Given this list of marker genes ZMYND8, ZNF804A, NEDD9, INS, APOE, here is a description of the gene set: Any process that activates or increases the frequency, rate or extent of dendritic spine maintenance. species: Homo sapiens Human Gene Set: GOBP_POSITIVE_REGULATION_OF_DENDRITIC_SPINE_MAINTENANCE